Given this list of marker genes Il4, Mettl21c, Meis3, Igbp1, Moap1 (NCBI Gene Id 78480), Steap3, Bcl2l14, Maz, Sort1, Hells, Tert, Il10, Bad, Eno1b, Tnfsf12, Chek2, Trp63, Gstp2, Mybbp1a, Rela, Prkcd, Cd28, Fxn, Bbln, Hdac2, Gnai3, Psen2, Nkx3-1, Cd74, Tmem14a, Tcf7l2, Parl, Tgfbr1, Pik3r1, Myc, Parp2, Ins2, Ddias, Nf1, Kcnq3, Trib3, Pink1, Bag5, Topors, Madd, Il19, Stk25, Clca3a2, Sh3rf1, Rps3, Snai2, Ngfr, Zfp622, Tlr3, Il18, Nono, Pou4f1, Skil, Fadd, Slc25a5, Vdac2, Trim39, Septin4, Siglec1, Htra2, Eef1e1, Bok, Card9, Dab2ip, G2e3, Pawr, Csnk2a1, Bcl2a1b, Ifi27l2b, Ifi208, Sgpp1, Ackr3, Sfn (stratifin), Tnfsf14, Hrk, Psme3, Dyrk2, Bag6, G0s2, Gata4, Mapk7, Fgg, Inhba, Atf4, Hmox1, Icam1, Ep300, Snw1, Triap1, Fbxw7, Jmy, Adcy10, Ell3, P2rx4, Mapk9, Mllt11, Cradd, Agap2, Brsk2, Bnip3, Ctsh, Slc25a4, Peli3, Gcg, Fbxo7, Il1b, Usp47, Eya2, Parp1, Map3k7, Dnm1l, Itgav, Opa1 (OPA1, mitochondrial dynamin like GTPase), Ing5 (inhibitor of growth family, member 5), Bmf, Tlr4, Kdm1a, Dnajc10, Tfpt, Acsl5, Bcl2a1a, Higd1a, Acaa2 (acetyl-CoA acyltransferase 2), Map3k5, Bax, Msh2 (mutS homolog 2), Esr2, Brca2 (NCBI Gene Id 12190), Scg2, Sfrp2, Pdia3, Il12a (interleukin 12a), Ggct, Il7, Col2a1, Siah2, Pla2g6 (phospholipase A2, group VI), Ppm1f, Anxa6, Nfe2l2, Camk2b, Tmem238l, Casp2 (caspase 2), Ikbkg, Mndal, Nck1, Rhot2, Ppp1ca, Eif2ak3, Ddx5, Uaca, Phlda3, Pak2, Ercc2, Eif2a, Umod, Tmbim1, Mtch2, Il20ra, Atad5, Xpa, Gstp-ps, Sod1, Tnfsf10, Ei24, Tnfrsf10b, Cx3cr1, Avp, Cxcl12, Bdkrb2, Fcgr2b, Srpx, Tm2d1 (NCBI Gene Id 94043), Casp9, Bcl3, Stk3, Atf2 (activating transcription factor 2), Ticam1, Uri1, Hyou1, Bcl2l10, Trap1, Crip1, Mdm2, Aen, Cd24a, Nme5, Pycard, Rb1cc1 (RB1-inducible coiled-coil 1), Mmp9, Krt18, Aldh2, Bmi1, Ptprc, Smad4, Eya3, Itprip, Epo, Mul1, Zfas1, Zfp110, Ndufs3, Fgb, AY074887, Mmp2, Msh6, Atf3, Sirt1, Nfkbiz, Tgfb2, Ltbr, Atp2a1, Rps6kb1, Tmbim6, Hgf, Tpd52l1, P2rx7, Bub1, Nanos3, Perp, Taf6, Ret, Gstp3, Ing2, Hyal2, Il3, Mif, Mfn2, Wnt5a, Hnrnpk, Dapk3, Diablo, Ifi27l2a, Inhbb, Pdk2, Mknk1, Daxx, Chac1, Raf1, Sfpq, Bag3, Polb, Phip, Syk, Ppp2r5c, Il33, Cdip1 (cell death inducing Trp53 target 1), D1Pas1, Mrtfa, Eaf2, Pik3cb, Zdhhc3 (zinc finger, DHHC domain containing 3), Armc10, Ngf (NCBI Gene Id 18049), Ripk1, Pnp, Gsk3b, Tmc8, Ero1a (NCBI Gene Id 50527), Siah1b, Becn1, Cdkn2d, Pidd1, Plscr1, Ppard, Casp3, Rnf7, Faf1, Gdnf, Lgals12, Bcl2l2, Pias4, Pten, Noc2l, Rps7, Psen1, Fbh1, Bid, Ifi203, Xbp1, Muc1, Tmem102, Prelid1, Sgk3, Stk4, Agt, Trp53bp2 (NCBI Gene Id 98424), Dnaja1, Osm, Il1a, Aatf, Prdx2, Ern2, Cav1, Pdcd5-ps, Pdcd5, Ptpn1, Hspa1b, Bnip3l, Fcmr, Agtr2, Nol3, Rffl (NCBI Gene Id 75134), Vhl, Plaur, Mapk8, Selenok, Il2, Fignl1, Cth, Fis1, Ifnz, Gsk3a, Mbd4, Usp28, Rpl26, Shh, Map2k5, Cck, Cd3e, Sod2, Epha2, Zmynd11, Itga6, Adora2a, Timm50, Casp12, Tnfaip3, Selenos, Tifab, Dbh, Trp53, Rnf41, Rps27l, Rrn3, Cx3cl1, Dedd, Map2k1, Gclc, Dapk1, Stk24, Fgfr1, Dapk2, Cd27, Bcl2l11, Hip1, Fasl, Pdpk1, Cd40lg, Eya4, Senp1, Cd5, Pdk1, Hspb1, Pam16, Eya1, Fzd1, Cdk11b, Sgpl1, Ddit3, Tnf, Marchf7, Ppef2, Rnf186, Mff, Gper1, Alox12, Gfral, Lck, Tnfrsf22, Ppp1r13b, Zfp385a, Bmyc, Bcl10, Pdcd10, Itm2c, Hdac1, Msx1, Nr4a2, Spn, Bmpr1b, Ghitm, Usp15, Rtkn2 (NCBI Gene Id 631847), Cdkn1a, Kcnq2, Bcl2, Gpx1, Fam162a, Fas, Rhot1, Snai1, Bcl2l1, Nck2, Gabarap, Ier3 (NCBI Gene Id 15937), Rack1, Vdr, Clu (NCBI Gene Id 28201), Flcn, Erbb3, S100a8, Fga, Ndufa13, Ifi206, Cyp1b1, Ctnna1, Plagl2, Rb1, Prkn, Rock2, Hipk1, Nrg1, Park7, Ifi203-ps, Runx3, Acvr1, Nherf1, Tnfrsf12a (tumor necrosis factor receptor superfamily, member 12a), Deptor, Mael, Lrrk2, Nlrp1b, Ctsc, Vnn1, Rad9a, Mlh1, Serinc3, Ddit4, Birc6, Tnfsf4, Hipk2, Ifi214, Jun, Sp100, Prkdc, Tradd, Hras, Nox1, Ubqln1, Dedd2, Wfs1, Bbc3, Pmaip1, Spi1, Grina, Hmgb2, Ccar2, Kitl, Gskip, Pmp22, Coa8, Nrp1, Nog, Crh, Foxo3, Ar, Wnt16, Ubb, Gsdme, Casp6, Rnf183, Lta, Maged1, Mcl1, Traf7, Csf2, Lmna, Traf2, Bex3, Ifi209, Bloc1s2, Ppp2r1a, Pou4f2, Ybx3, Ddx3x, Mknk2, Spop, Kdm6a, Knl1, Ifng, Fgfr2, Unc5b, Nlrp1a, Bcl2l12, Inca1, Ifi27, Ankrd2, Stradb, Pttg1ip, Fgf10, Nacc2, Cyld, Cttn, Yap1, Mapk8ip1, Cycs, Prkca (NCBI Gene Id 18750), Pdcd7, Eda2r, Ikbke, Slc35f6, Tnfsf15, Sh3glb1, Tgfb1, Qars1, Ptprv, Gstp1, Rrp8, Slc25a31 (solute carrier family 25 (mitochondrial carrier; adenine nucleotide translocator), member 31), Ptgs2, Ivns1abp, Fem1b, Casp8, Psmd10, Gata1, Smad3, Atm, Mapt, Chchd10, Pak5, Styxl1, Itpr1, Cflar, Fgfr3, Txndc12, Pea15a, Dele1, Casp8ap2, Asah2, Bcap31, Lgals3, Melk, Ltb, Ifnb1, Mnt, Wnt4 (wingless-type MMTV integration site family, member 4), Wnt1, Faim, Ifi207 (interferon activated gene 207), Trem2, Klf4, Jak2, Hif1a, Igf1, Faim2, Fyn, Ppif, Trp73, Map2k4 (NCBI Gene Id 26398), S100a9, Nbn, Ube2k, Pdx1, Cep63, Aifm1, Ddx47, Zfp385b, Gas1, Bik, Mdm4 (NCBI Gene Id 98570), Ifi204, Scn2a, App, Bcl2a1c, Ppia, Ptpn2, Mal, Creb3l1, Dapl1 (NCBI Gene Id 76747), Pde3a, Vegfa, Rrm2b, Tnfrsf23, Nodal, Dab2, Traf1, Rbck1, Mapk8ip2, Syvn1, Cyct, Plscr3, Apaf1, Atp2a3, Qrich1, Nupr1, Atp5if1, Creb3, Tnfrsf1b, Hip1r, Wdr35, P4hb, Fzd9, Hint1, Tnfsf11, Tlr6, Cd44, Tnfrsf4, E2f2, Prkra, Prodh, Arrb2, Fhit, Ifi213, Pcgf2, Eno1, Nfatc4, Brca1, Ptpmt1, Wwox, Lcn2, Bmp4, Zswim2, Tmem161a, Gclm, Fgf2, Akt1, Jak3, Atp7a, Erp29, Pml, Stx4a, Herpud1, Pycr1, Serpine1, Tnfrsf1a, Tpt1, Trim32, Trps1, Tmem117, Gnai2, Ube4b, Siah1a, Krt8, Bclaf1, Ripk3, Mpv17l, Ctnnb1, Cebpb, Cd70, Tmem109, Bdnf, Htt, Rnf34, Ptgis, Zfp13, Fnip2, Gsdma3, Siva1, Ppp2r1b, Faiml, Src (Rous sarcoma oncogene), Hic1, Shisa5, Acvr1b, Sfrp1, Acvr1c, Dap, Ercc6, Stk11, Bak1, Bcl2a1d, E2f1, Arl6ip5, Ern1, Thbs1, Dido1, here is a description of the gene set: Mouse Gene Set: GOBP_APOPTOTIC_SIGNALING_PATHWAY species: Mus musculus The series of molecular signals which triggers the apoptotic death of a cell. The pathway starts with reception of a signal, and ends when the execution phase of apoptosis is triggered.